Given this list of marker genes NRAS, PRKCZ, MAPK1, HRAS, KRAS, PDPK1, here is a description of the gene set: studied in species Homo sapiens Atypical protein kinases lack the calcium binding C2 domain and are unresponsive to diacylglycerol and phorbol ester, but instead respond to PIP3 generation downstream of PI3K signaling. Atypical protein kinase C zeta (PRKCZ) is activated downstream of estrogen stimulation is MCF7 breast cancer cells and contributes estrogen-dependent proliferation through MAPK pathway activation. part of: Extra-nuclear estrogen signaling Reactome Pathway: Estrogen-stimulated signaling through PRKCZ